Given this list of marker genes NFIL3, KLHL13, TBCCD1, PTBP2, PDS5B (PDS5 cohesin associated factor B), GABRB2, DTWD1, ZBTB14, MED24, RGPD8, SHB, FBXO4, EIF1AY, CCDC169, NEUROD6, PHF6, RADX, APMAP, MATR3, RNF139, PDE3A, KHDRBS1, NSRP1, HERC2, RFK, FBXO47, FBN1, ENPP4, SSBP2, CD164, ARHGAP5, SEC22C, PEG3, VAPA, SSH1, PTGFRN, SYTL4, PTPRN, CCNT1, LHX8, HILPDA, NHS, FANCL, ITGAM, ARL4A, KLHL2, CUL5, MED14, CYP51A1, FOXN3, TPRA1, LDLRAD3 (NCBI Gene Id 143458), EPG5, MBL2, ATAD2, RASSF8, RAI1, FFAR4 (NCBI Gene Id 353126, free fatty acid receptor 4), SLF2, PABIR2, METTL9, PDS5A, EP400, TMTC4, RGPD6, PHF21A, HHLA1, TIFA, TMEM108, RALGPS2, SNIP1, NOP16, TENT4B, TBRG1, FAM184A, GPR137C, PLAG1, BCOR, USP37, RAD51C, RUNX1T1, RFX3, SCAF11, HIPK1, PTH2R, RGPD5, P2RY13, IMPG1, ZCCHC2, EGR3, KHDRBS2, GOSR2, TFAP2C, CUL1, SEC31A, ADAMTS9, CEP135, PABIR1, PLXNA4, CEP350, DLG1, BCL6, DARS1, FBXO45, DLGAP4, TP63, PGM2L1, FSTL5, EIF2AK3, RGS4 (NCBI Gene Id 5999), SLITRK4, RORA, FAM120A, GCC2, ASXL1, DAAM1, ADCYAP1, GRB2, HOOK3, CR1, MACC1, TBX5, CDKL2, AHCTF1, DNAJC21, AKAP13, RGPD4, ELAVL4, ZNF789, KDM7A, PITPNB, SP4, TNRC6B, BPNT2, TMIGD1, TMEM245, MOSMO, ANKRD17, NR2C2, TRIM36, ZNF281, PCNX1, FAM177B, AFTPH, SUN2, RGPD3, PLAAT5, MID1, C1orf216, KCNA2, CAV2, RNF19A, MGAT4A, TENM2, ABCC6, ZNF529, PRKG1, KLF6, STRBP, SLC6A19, RNF38, RMND5A, CTNND1, PLCXD1, ABCB10, KIF2A, LARP4, SOCS6, SHROOM2, ABCC2, PEG10, TNRC6C, COL25A1, here is a description of the gene set: from publication Chen Y, Wang X (PMID 31504780) species: Homo sapiens Human Gene Set: MIR603 Genes predicted to be targets of miRBase v22 microRNA hsa-miR-603 in miRDB v6.0 with MirTarget v4 prediction scores > 80 (high confidence targets).